The following is a description of a gene set: Absence or underdevelopment of the nasal septum. species: Homo sapiens Human Gene Set: HP_APLASIA_HYPOPLASIA_OF_THE_NASAL_SEPTUM Aplasia/Hypoplasia of the nasal septum, and this is the list of marker genes: PTCH1, FLNB, NOG, SIX3, TGIF1